Given this list of marker genes JUN, MEF2A, TRAF6, TICAM2, RPS27A, TIRAP, IRAK3, DUSP4, N4BP1, CREB1, PELI2, NOD2, UBC (NCBI Gene Id 7316), SFTPA2, USP18, IRAK1, BTRC, FGB, PPP2R5D, ITGAM, MAP3K7, ITGB2, MAPK11, NKIRAS1, S100A1, FGA (NCBI Gene Id 2243), MAP3K8, MAPK10, TRAF3, RPS6KA3 (ribosomal protein S6 kinase A3), FBXW11, ATF1, ELK1, mip, MYD88, PELI3, DNM3, N, DNM1 (NCBI Gene Id 1759), PLCG2, IKBKG, MAPK14, SKP1, TAB1, USP14, NFKB2, NOD1, TAB3, TIFA, RELA, MAP2K6 (mitogen-activated protein kinase kinase 6), PPP2R1B, TLR6 (NCBI Gene Id 10333), FOS, NFKBIB, TBK1, DUSP6, RPS6KA5, MAPK9, PPP2CA, TAB2, NFKBIA, SOCS1, LBP (lipopolysaccharide binding protein), FGG, CD14, TLR1, RIPK1, ATF2, MAPKAPK3, RIPK3, IRF3, MAPKAPK2, RIPK2 (receptor interacting serine/threonine kinase 2), FADD, IRAK4, IRF7, PELI1, SAA1, TLR4, BPI, UBE2N, MAP2K3, TRAF2, IRAK2, CHUK, ALPK1, TLR2, PPP2CB, NFKB1, UBA52, BTK, MAPK3, UBE2D3, TICAM1, S100B, RPS6KA1, SARM1, NLRX1, LRRC14, S100A8, MAP2K4, S100A9, IKBIP, MAPK7, MEF2C, CASP8, SFTPD, MAP2K1, LY86, IKBKE, SIGIRR, AGER, TANK, BIRC3, TP53, BIRC2, LY96, RPS6KA2, UBE2V1, VRK3, DNM2, HMGB1, IKBKB, S100A12, OPTN, PTPN4, MAP3K1, UBE2D2, DUSP3, CUL1, TNIP2, PPP2R1A, CD180, PTPN11, DUSP7, SFTPA1, UBE2D1 (NCBI Gene Id 9335), ECSIT, NLRC5, UBB, APP, MAPK8, MAP2K7, porB, MAPK1, CD36, NKIRAS2, here is a description of the gene set: part of: Toll-like Receptor Cascades Toll-like Receptor 4 is a microbe associated molecular pattern receptor well known for it's sensitivity to bacterial lipopolysaccharides (LPS). LPS is assembled within diverse Gram-negative bacteria, many of which are human or plant pathogens. It is a component of the outer membrane of Gram-negative bacteria and consists of lipid A, a core polysaccharide and an O-polysaccharide of variable length (often more than 50 monosaccharide units). LPS is a potent activator of the innate immune response in humans, causing reactions including fever, headache, nausea, diarrhoea, changes in leukocyte and platelet counts, disseminated intravascular coagulation, multiorgan failure, shock and death. All these reactions are induced by cytokines and other endogenous mediators which are produced after interaction of LPS with the humoral and cellular targets of the host. In macrophages and dendritic cells, LPS-mediated activation of TLR4 triggers the biosynthesis of diverse mediators of inflammation, such as TNF-alpha and IL6, and activates the production of co-stimulatory molecules required for the adaptive immune response. In mononuclear and endothelial cells, LPS also stimulates tissue factor production. These events are desirable for clearing local infections, but when these various mediators and clotting factors are overproduced, they can damage small blood vessels and precipitate shock accompanied by disseminated intravascular coagulation and multiple organ failure. studied in species Homo sapiens Reactome Pathway: Toll Like Receptor 4 (TLR4) Cascade